Given this list of marker genes CCL20 (C-C motif chemokine ligand 20), PTGES (prostaglandin E synthase), PPL, ADIRF, CPE, FOXG1, PTGS1, KRT13, CDA, HSPG2, PLAC8, PEG10, AQP3, CRYBG2, TFPI, GPRC5A, HR, FARP1, here is a description of the gene set: from publication Azare J, Leslie K, Al-Ahmadie H, Gerald W, Weinreb PH, Violette SM, Bromberg J (PMID 17438134) Genes down-regulated in RWPE-1 cells (prostate cancer) upon expression of constitutively active form of STAT3. species: Homo sapiens Human Gene Set: AZARE_NEOPLASTIC_TRANSFORMATION_BY_STAT3_DN The persistent activation of signal transducer and activator of transcription 3 (Stat3) is a common feature of prostate cancer. However, little is known about the Stat3 targets that may mediate prostate tumorigenesis. The introduction of an activating mutant form of Stat3 (Stat3-C) into immortalized prostate epithelial cells resulted in tumorigenesis. Stat3-C-expressing cells had decreased E-cadherin levels, increased numbers of lamellipodia and stress fibers, and enhanced migratory capacities compared to vector control-expressing cells, with a concomitant increase in the expression of integrin beta6 and its ligand, fibronectin (FN). Exogenously added FN increased cellular migration, with a concomitant loss of E-cadherin expression. The blockade of integrin alphavbeta6 in Stat3-C-expressing cells inhibited migration, increased E-cadherin levels, and reduced colony formation in soft agar. These results demonstrate the sufficiency of constitutively activated Stat3 in mediating prostate tumorigenesis and identify novel Stat3 targets that are involved in promoting cell migration and transformation.